The following is a description of a gene set: RB1 regulates mitotic exit by acting on SKP2, a component of the SCF E3 ubiquitin ligase complex. RB1 facilitates degradation of SKP2 by the anaphase promoting complex/cyclosome (APC/C), thus preventing SKP2-mediated degradation of the cyclin-dependent kinase inhibitor CDKN1B (p27Kip1). RB1-dependent accumulation of p27Kip1 plays an important role in mitotic exit and RB1-mediated tumor suppression. part of: Aberrant regulation of mitotic cell cycle due to RB1 defects Reactome Pathway: Aberrant regulation of mitotic exit in cancer due to RB1 defects species: Homo sapiens, and this is the list of marker genes: ANAPC1, CDC27, ANAPC4, ANAPC11, ANAPC2, SKP2, ANAPC16, ANAPC7, ANAPC15, UBE2D1, UBE2C, UBE2E1, FZR1, CDC26, UBE2S, ANAPC5, ANAPC10, RB1, CDC16, CDC23